The following is a description of a gene set: part of: TAK1-dependent IKK and NF-kappa-B activation   studied in species Homo sapiens Nuclear factor kappa B (NF-kappa-B, NF-κB) is activated by a diverse range of stimuli including cytokines, ligands of pattern-recognition receptors (PRRs) such as Toll-like receptors (TLRs) in myeloid cells, antigen-activated TCR in T-cells and by DNA damage. NF-kappa-B regulates the transcription of genes that are involved in immune and inflammatory responses, cell cycle, cell proliferation and apoptosis (Bhatt D & Ghosh S 2014; Liu T et al. 2017; Yu H et al. 2020). In unstimulated cells, NF-κB is sequestered in the cytosol through interactions with a class of inhibitor proteins, called NF-κB inhibitors (IkBs, such as NFKBIA or NFKBIB) (Jacobs MD & Harrison SC 1998). IkBs mask the nuclear localization signal (NLS) of NF-κB preventing its nuclear translocation (Cervantes CF et al. 2011). A key event in NF-κB activation involves phosphorylation of IkBs by the IκB kinase (IKK) complex which consists of CHUK, IKBKB and IKBKG subunits (Israël A 2010). The activated NF-κB signaling is tightly controlled at multiple levels (Dorrington MG & Fraser IDC 2019; Prescott JA et al. 2021). Dysregulated NF-κB activity can cause tissue damage associated with inflammatory diseases and is also linked to tumorigenesis (Aggarwal BB & Sung B 2011; Liu T et al.2017; Barnabei L et al. 2021). The regulation of NF-κB is cell-type-, context-, and stimulus-dependent and is crucial for orchestrating specific cellular responses (Mussbacher M et al. <br><br> Reactome Pathway: Regulation of NF-kappa B signaling, and this is the list of marker genes: N4BP1, NLRC5, TRAF6, NLRX1, TP53, LRRC14, USP14, IKBKB, TRAF2 (TNF receptor associated factor 2), CASP8, USP18, RPS27A, CHUK, UBC, UBA52, UBB, IKBKG, IKBIP